The following is a description of a gene set: from publication Wirth TC, Xue HH, Rai D, Sabel JT, Bair T, Harty JT, Badovinac VP (PMID 20619696) The transcriptome of naive OT-I T cells was compared to memory CD8 T cells after 1, 2, 3, or 4 infection with ovalbumin expressing Listeria monocytogenes (LM-OVA). species: Homo sapiens Genes up-regulated in memory CD8 T cells: 1' versus 3'. Human Gene Set: GSE21360_PRIMARY_VS_TERTIARY_MEMORY_CD8_TCELL_UP, and this is the list of marker genes: CD300C, BRF1, EXTL3, ASIC1, PHLDA1, NUDC, SLC7A8, SDR39U1, TLE3 (TLE family member 3, transcriptional corepressor), AKR1C3, TBC1D12, NADK, ARHGEF2, BAP1, HSF2, CNPPD1, SH3BP1 (NCBI Gene Id 84161), ZFP36L2, ALDH3B1, TCEA1, NQO1, ARAP1, POP5, NCOR2, ZNF623, PEX7, GNA12, UCK2, RXRA, LETMD1, CD180, USP22, DGCR2, HS3ST1 (heparan sulfate-glucosamine 3-sulfotransferase 1), TRAM1, ACP2, CLPTM1, BBLN, LYL1, PLIN2, RETREG3, DHPS, DNMBP, MAP2K1, SCAMP1, RBM14, CCT7, ABCC1, TESK1, MAPK13, ARHGDIB, CIAO1, SLC36A1, PARVB, BTF3, PLA2G15, TWF2, NKRF, UBAC1, SNW1, TARBP2, SERPINE1, CHD8, RAP1GDS1, PHB2, POLD2, RAB5B, SLC7A6, NOTCH3, PPP1CA, WBP1L, EXOSC2, KIF13B, ZNF821, YWHAH, LSM2, SEC62, DNASE1L1, DGKD, LPL, USF2, EREG, AP2M1, RPL15, ENG, RUSC1, ST3GAL6, PCNA, MFSD5, AFG3L2, RBM12, ACADVL, PURA, LAIR2, SUPT4H1, RGS19, NFATC3, SQSTM1, CBFA2T2, KDM3A, ZFP36L1, FARSA, COA1 (cytochrome c oxidase assembly factor 1), MNT, DOK1, ADORA3, MYO1F (myosin IF, NCBI Gene Id 4542), NPAT, RPP40, LRRC41, ATOSB, HTR2B, ODC1, MRPS12, ZFAND5, SMARCD2, SLC22A4, IFIT1, TATDN2, PIK3R1, CLPX, PLEKHO2, MTMR1, CTPS1, PLEC, CDK9, CHST15, SORL1, BOLA2, CYP27A1, XPOT, FCGR3A, PIBF1, ZNF292, SLC6A6, SFXN3, SLC16A3, TNFRSF11A, KAT7, ID3, SYNJ2, FOXO3, TREX1, CDK4, AQP9, SGSH, HPCAL1, BMP2K, SNHG29, MLXIP, POLRMT, RGS12, RHOG, DDIT4, TNFSF14, FCMR, MAPK14, PTGIR, RAC2, POLR2J, MPRIP, GGA3, CA2, HIP1, ZNF137P, RDH11, FOXO1, ACO2, MITF, LAIR1, TLR5, CSK, HMOX1, ACTR1B, ARF1, LYPLA2, PHC2, LAGE3, PTPN22, IKBKE, SNRPC, POP1, MARCKSL1, PLK2, DTX2, TCF12, MGLL, C1QBP, CXCR4, CLIP2, POU2F2, THBD, ABR, EIF3B, ABCG1, OGT, SLC25A6 (NCBI Gene Id 8283), URB2, CHD4, KLHL21